Given this list of marker genes BEST4, GABRB2, CLCN1, GABRG1, CLCNKA, CLCN2, ANO2, GABRE, CLDN4, BEST3, GLRA2, CFTR, GABRB1, SLC17A8 (NCBI Gene Id 64944), GLRA1, CLDN17, SLC17A6, GABRA6, GABRR3, GABRR2, TTYH1 (tweety family member 1), GABRG3, GABRA2, MFSD8, BEST2, GABRD, TTYH3, GLRB, GABRG2, SLC26A6, ANO1, GABRA5, GLRA3, OSTM1, GABRB3, CLIC3, GABRA1, GABRA3, CLIC1, TTYH2, BEST1, CLCN7, CLCNKB, SLC17A7 (solute carrier family 17 member 7), CLIC2, ANO6, GABRR1, GABRA4, CLIC5, CLIC4, GABRQ, CLCC1, PACC1, CLIC6, GABRP, here is a description of the gene set: species: Homo sapiens Human Gene Set: GOCC_CHLORIDE_CHANNEL_COMPLEX An ion channel complex through which chloride ions pass.